The following is a description of a gene set: Although disruption of histone modification patterns is a common hallmark of human cancer, our knowledge of the mechanistic role of histone-modifying enzymes in its generation is very limited. We have recently identified an inactivating mutation in the histone deacetylase-2 (HDAC2) in sporadic carcinomas with microsatellite instability and in tumors arising in individuals with hereditary nonpolyposis colorectal cancer syndrome. Since HDAC2 seems to be a central player in epigenetic gene repression, we wondered whether HDAC2-truncating mutations conferred a particular expression signature on these cancer cells. Using unsupervised clustering analysis in microsatellite-unstable colorectal cancer cell lines, we have found that HDAC2 mutant cells (RKO and Co115) show a characteristically different expression microarray signature from HDAC2 wild-type cells (HCT-116, SW48, HCT-15 and LoVo). HDAC2 mutant cells exhibit upregulation of tumor-promoting genes, such as those of tyrosine kinases, mediators of cell cycle progression and angiogenic factors. The overexpression of these genes is associated with a loss of HDAC2 recruitment and a gain of histone H4 hyperacetylation in their particular 5'-end promoters, as observed by chromatin immunoprecipitation. Transfection of wild-type HDAC2 in mutant cells reverted this epigenetic pattern by repressing the transforming genes in association with HDAC2 promoter occupancy. These results suggest a role for HDAC2 mutations in human tumorigenesis through the derepression of key genes from multiple cellular transformation pathways. Genes up-regulated genes in cell lines with HDAC2 loss of function (LOS). species: Homo sapiens Human Gene Set: ROPERO_HDAC2_TARGETS from publication Ropero S, Ballestar E, Alaminos M, Arango D, Schwartz S Jr, Esteller M (PMID 18264134), and this is the list of marker genes: APOA2, OR1F2P, TNFAIP2, GIP, CCDC85B, AP1S2, ADCY10, TRGC2, PTHLH, SNAPC1, GZMB, PART1 (NCBI Gene Id 53948), CDC42BPA, AQP4, MOG, SLFN12, UBQLN3 (NCBI Gene Id 50613), TLR6, FGF14, SLC6A2, ASAP1, EPHA2, IGFBP7, MGAM2, BIRC7, CCDC88C, SEL1L, NEK3, PCDHGA9, CHIC2, FCAR, CKMT2, SMAD6, PPOX, ST3GAL1, RABEPK, TBX2, UCHL3, DOP1A, TM6SF1, DPY19L1P1, DLEC1, PDE4D, EMP3, COMP, WNT6, ZCCHC4, B4GALT6, STEAP1B, SEPTIN6, KLK13, ZSCAN18, ACHE, MAG, PBX2, PCNX2, SPTBN2, BNIP3L, TADA2A, RPS20P14, GCFC2, MMP16, MACF1, EIF4EBP1, MORN1, GNLY, KCNK3, RAD52, AP5Z1, NADK, SERGEF, GSS, HSPA13, PPP2R1B, APLP1, TXNIP, INS, CORO2B, FUT5, FIBP, PLA2G5 (NCBI Gene Id 5322), RBFOX2 (RNA binding fox-1 homolog 2), EEF1D, KCNJ6, HAPLN1, MYRF, NPY2R, TNXB, RBPMS, GP2, PTPA, TCL6, NCOA4, PDX1, EEF1AKMT2, BAHCC1, CORO1C, APOL2, CEP57, FANCE, CYP2D6, MDM2, GFUS, TMEM209, TXNRD2, SHARPIN, C11orf68, SLC22A6, STMN2, ADD3, RUNX1, DGCR6L